Given this list of marker genes PARVG, RPS10 (ribosomal protein S10), TLK1, MMS19, HSD17B11, TBRG1, USP34, FASTKD1, TSPAN32, SYT7, ATM, POLR3B, SF1, MAP3K1, UQCRH, LASP1, MXI1, N4BP2L1, GNPTAB, HOXA10, RBL2, ADD3, KCNA3, ADAT1, CBLB, SELL, DMXL1, PTGER2, ASF1A, IDS, OGA, ULK4, EVI2B, TIFA, RENBP, ITGAV, RIPK4, GPCPD1, FOXO1 (forkhead box O1), MPZL1 (myelin protein zero like 1), RNPC3, PDLIM3, CHD7, ZRANB2 (zinc finger RANBP2-type containing 2), UBXN11, KLF8, SSH2, ANKRD53, PTPN22 (NCBI Gene Id 5779), G6PC3, HEATR6, WRAP53, PPP3CC, USPL1, PTTG1, HELQ, RASA1, PIK3CA, here is a description of the gene set: Human Gene Set: MODULE_237 Genes in the cancer module 237. species: Homo sapiens